The following is a description of a gene set: Human Gene Set: MIR200B_5P Genes predicted to be targets of miRBase v22 microRNA hsa-miR-200b-5p in miRDB v6.0 with MirTarget v4 prediction scores > 80 (high confidence targets). species: Homo sapiens from publication Chen Y, Wang X (PMID 31504780), and this is the list of marker genes: HOXA10, PKP2, SLC25A40, INSIG2, KLF7, DNAJC27, SERINC3, HAUS6, NCF2, ATG10, ZNF440, MOBP, PCDHB6, ETFDH, BTBD1, CRLF3, KIAA1217, ZNF99, ZNF396, SP3, ZNF770, ZC3H12C, HIVEP3, EIF4ENIF1, SNX4, PPM1E, LRRC57, ASNSD1, SHPRH, EID1, AHR, OPRM1, TXNDC17, COPS8, GRK3, KLHL5, KCTD12, MORC3, ZNF91, ATAD2, SULT1C2, HPDL, AGPAT5, NDFIP2, RANBP3, BBX, SCOC, ZNF675, IL1RAP (NCBI Gene Id 3556), NDFIP1, SGK1, TXNRD3, MDFIC, HCFC2, KMT2E, ARC, SH3RF1, IFT52 (NCBI Gene Id 51098), NSG2, PAPOLG, ZNF254 (zinc finger protein 254), COL4A1, UBR3, EPM2AIP1, ZNF208, TASOR2, FGF13, NFIA, NR4A1, NSD2, MIER3, CHD7, ZNF367, RAB11B, ZNF138, KDM2B, USP53, ENKUR, GRHL1, AMMECR1, ATP6V0A2, BICRA, THAP5, EIF1AX, RAB1A, MYBL1, EPHA5, LMTK2, SEMA3E, BEST3, TIAM2, CRIM1, FOXD1, TMEM39A, ZNF493, FOXC1, ZNF763, POU2AF2, GOLGA7B, SLC22A15, ARL13B, ALX4, PLPP3, LIMCH1, PPRC1, C18orf54